Given this list of marker genes MEF2C, GZMA, ANXA1, TMSB10, SUCLG1, MPO, UBE4A, SELPLG, PSME2, PSMB9, SOX4, STIP1, HINT1 (NCBI Gene Id 3094), AHR, here is a description of the gene set: Acute promyelocytic leukemia (APL) is associated with chromosomal translocations involving retinoic acid receptor alpha (RAR alpha) and its fusion partners including promyelocytic leukemia (PML) and promyelocytic leukemia zinc finger (PLZF). Using oligonucleotide arrays, we examined changes in global gene expression mediated by the ectopic expression of either PML/RAR alpha (retinoid-sensitive) or PLZF/RAR alpha (retinoid-resistant) in U937 cells. Of more than genes analyzed, genes were commonly up-regulated, and genes were down-regulated by both fusion proteins suggesting their role in the APL phenotype. In our APL model, for example, TNFAIP2, TNFR2, ELF4, RAR gamma, and HoxA1 were down-regulated by both fusion proteins in the absence of retinoic acid (RA). RA strongly up-regulated these genes in PML/RAR alpha, but not in PLZF/RAR alpha expressing U937 cells. Expression studies in NB4, retinoid-resistant NB4-R2, normal human CD34+ cells, and APL patient samples strongly suggest their role in the regulation of granulocytic differentiation. Furthermore, combined treatment with tumor necrosis factor alpha (TNF alpha) and RA synergistically enhanced granulocytic differentiation in NB4 cells but not in NB4-R2 cells. Our data indicate that APL pathogenesis and retinoid-induced granulocytic differentiation of APL cells involve genes in the cell death pathway, and that cooperation between the RA and TNFalpha signaling pathways exists. Targeting both the retinoid-dependent differentiation and the cell death pathways may improve leukemic therapy, especially in retinoid-resistant acute myeloid leukemia. Genes up-regulated in U937 cells (acute promyelocytic leukemia, APL) expressing RARA fused with either PML or PLZF. studied in species Homo sapiens Human Gene Set: PARK_APL_PATHOGENESIS_UP from publication Park DJ, Vuong PT, de Vos S, Douer D, Koeffler HP (PMID 12893766)